Given this list of marker genes Krt26, Cxcl5, Eef1a1, Speg, Ddx25, Gpr141b, Slc30a7, Kif4, Tet3, Ap3d1, N4bp1 (NCBI Gene Id 97462), Irag1 (NCBI Gene Id 233729), Nck1, Tbcd, Zfhx4, Orai2, Vwc2l, Onecut2, Fermt1, Fat3, Sfrp1, Tsc22d1, Or4d10c, Sprr2f, Gria4, Peli2, Dcbld2, Gpr174, Zfp239, Acox1, Spats2l, Grsf1, Lpp, Rps15a, Tlr4, Krr1, Fhod3, Nudt7, Elavl2, Pgk2, Smurf2, Sgk3, Jade2, Cnnm4, Mtcl2, Plekhm3, Spindoc, Kpna3 (karyopherin subunit alpha 3), Angpt2, Cngb3, Mylip, Mpig6b, Hecw1, Tmem132b, Dmxl1, Cryzl1, Mnat1, Rit1, Pten, Hipk3, Rnf170, Sprr2i, Tsr2, Cyp4a12a, Zcchc17, A4gnt, Pom121l2, Vwce, Unc80, Fbxo9, Cyp4a12b, Ube2e1, Tent5d, Slain2, Rora, Nexmif, Susd6, Apbb2, Alcam, Zfp618, Sun2, Rps6kb1, Cep164, Meis1, Nup98, Magea10, Ppil3, Capza3, Ivd (isovaleryl coenzyme A dehydrogenase), Fbxw11, Zfhx3, Rab38, Zfp874a, Arhgap5, Zfp677, Armt1, Gprin1, Zfp184, Rimoc1, Pbx1, 9530068E07Rik (RIKEN cDNA 9530068E07 gene), Krtap6-1, Vps26b, Mindy2, Slc35f6 (solute carrier family 35, member F6), Slc7a8, Armc8, Gabarap, here is a description of the gene set: studied in species Mus musculus Mouse Gene Set: MIR_542_3P from publication Chen Y, Wang X (PMID 31504780) Genes predicted to be targets of miRBase v22 microRNA mmu_miR_542_3p in miRDB v6.0 with MirTarget v4 prediction scores > 80 (high confidence targets).